The following is a description of a gene set: studied in species Homo sapiens Human Gene Set: HP_SEVERE_FAILURE_TO_THRIVE Severe failure to thrive, and this is the list of marker genes: ERCC6, PRPS1, CLCNKA, FIG4, RTTN, LMNA, CLCNKB (NCBI Gene Id 1188), PEX7, ASXL1 (ASXL transcriptional regulator 1), UNC80, ZMPSTE24, HYMAI, CENPJ, VAC14, ZFP57, BSND, NALCN